Given this list of marker genes ETS1, CSNK2A2, NLK, SP3, QKI, MIER3, TTN, MED13, here is a description of the gene set: studied in species Homo sapiens Genes having at least one occurence of the motif CGTCTTA in their 3' untranslated region. The motif represents putative target (that is, seed match) of human mature miRNA hsa-miR-208 (v7.1 miRBase). Human Gene Set: CGTCTTA_MIR208